Given this list of marker genes AP3B1, DTNBP1, BLOC1S1 (NCBI Gene Id 81990), BORCS5, BLOC1S4, MAP2, AP3M2, TRIM46 (NCBI Gene Id 80128), AP3S2, AP3D1, AP3B2, AP3M1, BLOC1S2, BLOC1S6, BLOC1S5, AP3S1, KIF1B, BLOC1S3, SNAPIN, here is a description of the gene set: Human Gene Set: GOBP_SYNAPTIC_VESICLE_CYTOSKELETAL_TRANSPORT The directed movement of synaptic vesicles along cytoskeletal fibers such as microfilaments or microtubules within a cell, powered by molecular motors. studied in species Homo sapiens